Given this list of marker genes MAP2K2, PDCD10, VRK1, PLK1, CDK1, MAPK1, VCPIP1, MAP2K1, YWHAZ, PLK3, MAPK3, VPS13B, GOLGA2, STX5, STK25, GBF1, here is a description of the gene set: Human Gene Set: GOBP_ORGANELLE_INHERITANCE The partitioning of organelles between daughter cells at cell division. studied in species Homo sapiens